Given this list of marker genes COL24A1, CIAO2B, APOC2, MMP2, TK1, TDRD1 (tudor domain containing 1), SAP30, RGS4, FHL1, SLC25A37, ROM1, CTU1, SPG21, FMNL3, USP4, C19orf12, TRIM8, ARRDC4, PTGES, EPHA4, EGR1, OLR1, CPLANE1, GNAZ, NDUFA3, TMEM176A, MIF, MAPKAPK2, CBLN3, CRYBG1, SHISA2, SGCE, VEGFA, PML, RASGRP1, CAMK2N1, SMAD3, SERPINF2, MAFF, CCT7, NINJ2, WBP2, STOML1, RABEPK (NCBI Gene Id 10244), EPN2, CGNL1, ADAM19, TLR1, SAMSN1 (NCBI Gene Id 64092), NFASC, GPT2, C8orf76, PIGZ (phosphatidylinositol glycan anchor biosynthesis class Z), DAD1, GAL3ST4, PI16, MEX3B, SSTR5, PKD1L2, PTPN6, ENPP4, KCNT2, CKS1B, PLAT, RPS5, SMS, TES, PAH (phenylalanine hydroxylase), TRAF3IP1, BDNF, PMEPA1, IGFBP7, NDUFS6, SCARA3, TMPRSS4 (transmembrane serine protease 4), MBOAT7, ABCC3, ANXA6, PCDH7 (protocadherin 7), TREML4, TMEM121, MARCHF11, HMGCS2, SLC16A10, DOHH, SPINK5, MDM4, MAD2L1, SLC38A4, E2F1, ACOD1, KRTAP8-1, FAM167B, SLC30A9, IQGAP3 (NCBI Gene Id 128239), SLC24A3, ZFAND3, CD52, RARB, NUDT5, CNBP, KLHL6, COPS8, PRSS21, GFI1, OSM, LRP2, RND1, PFKL, AP1S1, MFNG, ELL, POLE3, NRIP1, FLYWCH2, SCN1A, LYPD6, HPX, SOCS2, NFKBIB, RBM10, KRTAP3-1, NKX3-1, CXCL13, PAMR1, SEMA4C (NCBI Gene Id 54910), ZNF804A, KCNH1, NOD1, NFKBID, ZNF250, DCLK3, RNF157, LSM11, AMER3, GALNT3, TMTC4, CD79B, SEC14L1, BMP2, RAC2, TBXAS1, IDH1, TINAGL1, MANF, CXCL10, EPHX1, NFKB1, COL14A1, BLNK, NPTX1, IRGM, SLC25A20, CX3CR1, FAM78B (family with sequence similarity 78 member B), CCDC33, PLD4, PLOD3, VKORC1, FAM3A, B4GALNT1, C11orf54, CAD, PRKCG, PPBP, ITM2C, RIN1, CCT8 (NCBI Gene Id 9888), CRPPA, SAPCD1, TMEM125, P2RY14, MCM3, IRAK2, CP, SERPINB8, HIBADH, HS6ST1, TMEM70, PEX19, TAPBP, MUC1, NIPSNAP1, ALDOA, NID1, GBP7, CYRIB, KRT85, MLLT6, RPL18A, BAG1, SLAMF9, CFH, LY96, ABHD10, APRT, HAP1, IL22, TGM4, ETHE1, here is a description of the gene set: Genes down-regulated in cortical thymic epithelial cells (cTEC) versus thymic dendritic cells. studied in species Homo sapiens Gene expression in different thymic stromal cells and subsets thereof was analyzed in 6-12 week old wild type (C57BL/6) and Aire knock-out (mixed background) mice. Thymic stromal cells were purified by sequential enzymatic digestion (collagenase, collagenase/dispase and trypsin) followed by gradient centrifugation and FACS sorting. Sort criteria were as follows: dendritic cells (CD11c+, F4/80 -), macrophages (F4/80+, CD11c-), cTECs (CD45–/lo, CDR1/Ly51+, Ep-CAM+) and mTECs (CD45–/lo, CDR1/Ly51–, Ep-CAM+). mTECs of wild-type and Aire knock-out mice were further subdivided according to CD80 expression levels. For microarray analysis total RNA from thymic stromal cell samples of two independent experiments was pre-amplified and biotinylated by two rounds of cDNA synthesis and in vitro transcription. Fluorescence readings were evaluated by using Microarray Suite 5.0 software. Human Gene Set: GSE2585_CTEC_VS_THYMIC_DC_DN from publication Derbinski J, Gäbler J, Brors B, Tierling S, Jonnakuty S, Hergenhahn M, Peltonen L, Walter J, Kyewski B (PMID 15983066)